Given this list of marker genes Ddx6, Pdgfra, Phf3, Stxbp5, Reps2, Relch, Chst1, Wnt2b, Acsl1, Thsd7a, Btbd3, Zfp655, Maf, Gja1, Smoc2, Btg1, Rap2c, Larp4, Ppp6r1, Ldaf1, Med15, Arhgap1, Itpr1, Cltc, St8sia5, Prr14l, Nectin3, Rnf38, Dll1, Dsel, Fibin, Pou4f1, Ccny, Nacc2 (nucleus accumbens associated 2, BEN and BTB (POZ) domain containing), Epc2, Mbnl1 (muscleblind like splicing regulator 1), Mb21d2, Blcap, Mapk1, Ankib1, Lonrf1, Casd1, Ago4, Klhl20, Ube2d2a, Clcn5, Pmepa1, Cfl2, Ptprg, Laptm4a, Cbfb, Garem1, Lonrf3, Abcc5, Iqgap2, Atg16l1, Mdm4, Lgalsl, Hoxb1, Togaram1, Ptp4a1, Erbin, Stim2, Map3k12, Gpr137c, Emx2, Sowahb, Cdk19, Brwd1, Snapin, Sh3d19, Sbno1, Mfsd6, Pcnx1, Vps37a, Miga2, Mctp1, Hprt1, Pxk, Arhgap21, Phaf1, Skida1, Tet3, Tbc1d12, E2f2, Gon4l, Mapk8, Tbl1xr1, Cast, Prkd3, St18, Mat2b, Map3k8, Elk3, Tshz1, Zfp113, Memo1, Psap, Eogt, Spart, Gpatch8, Sybu, Atp2b2, Mdn1, Mecp2, Ereg, Mid1ip1, Npepl1, Mon2, Jarid2, Vps29, Tes, Lrp8, Daam1, Mmgt1, Lcorl (ligand dependent nuclear receptor corepressor-like), Cpeb1, Tmem250, Robo2, Csnk1g1, Acsl4, Dpysl2, Kmt2c, Ago1, Sulf1, Ar, Cmpk1, Adamts20, Sphk2, Nsd3, Tsc1, Psd, Stimate, Ubl3 (NCBI Gene Id 24109), Naa30, Arhgap12, Pparg, Sgcb, Kbtbd8, Rfx7, Acvr1, Socs5, Ccdc126, Dcbld2, Tbc1d8, Rnf216, G3bp2, Phf12, Wnk1, Tapt1, Smarcd2, Il25, Kcnj2, Tnf, Prkaa1, Snip1 (Smad nuclear interacting protein 1), Csmd1, Smoc1, Cyld, Rasd1, Rab5a, Abhd3, Zmat3, Usp32, Stx6 (NCBI Gene Id 98448), Mllt6, Calm2, Appl1 (NCBI Gene Id 97938), Fmr1, Fermt2 (NCBI Gene Id 218952), Jade1, Slmap, Dnajc24, Nol4, Fut9, Akirin2, Mdfic (NCBI Gene Id 16543), Fcho2, Snx5, Kcna4, Rtn1, Usp8, Mex3d, Med12l, Atxn1, Impdh1, Fastk, Ston2, Tspyl2, Zbtb4, Snx2, Cds1, Neurog1, Lrp4, Gga3, Zfp11, Ulk2, Bnip2, Plekhg5, Cd69, Wdfy3, Kdm2a, Dennd1a, Spire1, Tbcel, Smad5, Hs3st5, Arap2, Psd3, Akap11, Pak6, Zcchc14, Gng12 (guanine nucleotide binding protein (G protein), gamma 12), Pik3cb, Btaf1, Heg1, Adcy1, Btbd7, Nckap5, Dennd10, Acer2, Sel1l3, Clip1, Plcb1, Mybl1, Zfp609, Acbd5, Fam234a, Ldlrad4, Enpp5, R3hdm1, Lrrtm2, Wee1, Zbtb18, Mphosph9, Pgm2l1, Tgfbr1, Cnot6, Lrig1, Jmy, Cnot7, Eda, Cep170, St6galnac3, Spred1, Tnrc6c, Esr1, Dgke, Socs6, Btf3l4, Caprin2, here is a description of the gene set: studied in species Mus musculus Mouse Gene Set: MIR_130C Genes predicted to be targets of miRBase v22 microRNA mmu_miR_130c in miRDB v6.0 with MirTarget v4 prediction scores > 80 (high confidence targets). from publication Chen Y, Wang X (PMID 31504780)